The following is a description of a gene set: Reactome Pathway: Cytokine Signaling in Immune system Cytokines are small proteins that regulate and mediate immunity, inflammation, and hematopoiesis. They are secreted in response to immune stimuli, and usually act briefly, locally, at very low concentrations. Cytokines bind to specific membrane receptors, which then signal the cell via second messengers, to regulate cellular activity. part of: Immune System species: Homo sapiens, and this is the list of marker genes: TRIM48, PPP2CB, UBE2V1, MX2, PSMB6, PIK3R1, CNTFR, IL13RA1, SMARCA4, S1PR1, UBA52, ILF3, S100A12, TRAF2, CD4, UBB, GBP2, PELI1, IRS2, TYK2, VRK3, AKT3, PTK2B, PTPN13, IFNGR2, TUBB2A, SQSTM1, NKIRAS2, TNFSF18, GHR, NUP37, IL11RA, NUP205, IRF8, LCK, IL27RA, STAT1, TGFB1 (transforming growth factor beta 1), IL12B, GBP4, NPM1, PSMD14, UBE2D2, EDA2R, FAAP24, IL7, NUP42, PRLR, IFNGR1, SH2B1, CSF2RA, LTBR, CLCF1, CAMK2A, EIF2AK3, ADAM17, GRB10, RHOU, HGF, CCL22, FOXO1, CCL3L1, ITGB1, PSMB1, EBI3, MAPK9, ATF2, STAT3, CHUK, NUP35, EIF2AK2, NUP210, FNTA, PTPN18, IL6, IL13, IL15RA, TUBB2B, FANCM, PRL, HSPA1A, NCK1, EIF4A2, PTPN6, CD27, IKBKG, TIMP1, IFNA1, MSN, IP6K2, PTPN7, IL1RAPL1, UBE2I, PSMD6, FOS, UBE2N, POM121C, IL20, PIN1, SKP1, IL15, BCL2L11, CSF2, INPP5D, HNRNPF, MCL1, MAP2K6 (NCBI Gene Id 5608), IRF9, GH1, BCL2L1, FASLG, HSPA2 (heat shock protein family A (Hsp70) member 2), TNF, CCR1, IL18RAP, CAPZA1, IFIT1, NUP133, SYK, SNCA, YES1, SLA, TNFRSF4, NEDD4, MAPKAPK3, VTRNA2-1, PSMD7, PGGT1B, IRF4 (NCBI Gene Id 4592), TUBA1A, CDC42, SOX2, PTPN12, NUP93, HSPA1B, GBP1, OAS1 (2'-5'-oligoadenylate synthetase 1), LRRC14, MMP2, IFI35, RAP1B, PSMC2, MIF, ALOX5, TNFSF4, GAB2, TRIM25, IRAK3, FN1, PSMC4, EIF4A3, MAPK14, YWHAZ, IL21, HLA-DRB4, CD86, FANCE, IL36B, IL2RB, NDC1, PSMA2, IFNAR2, NFKBIA, PTPN14, TRIM35, HLA-B, FGF2, OPRD1, TRAF3, PELI3, TNFRSF25, IL6R, TALDO1, SPHK1, MAPK7, TNFRSF8, NUP88 (nucleoporin 88, NCBI Gene Id 4927), BECN1, CCND1, TNFSF14, PSMB7, NLRC5, KPNA4, NUP107, KRAS, PSMA3, GATA3 (GATA binding protein 3), TXLNA, IL9R, MX1, ISG20, CSF2RB, BLNK (B cell linker), SOS2, SERPINB2, TNFRSF14, FAAP20, IL17C, TUBA4A, PSMD3, CUL1, PRKACA, PDE12, IL2RG, GSTO1, LIFR, MUC1, OASL, AAAS, GBP5, IL12A, EIF4E2, IFNA16, JAK3, S100B, AKT2, MAP3K3, MAVS (mitochondrial antiviral signaling protein), FYN, RAG1 (NCBI Gene Id 5896), SOD2, IL33, BST2, IRF7, RNASEL, UBA7, ADRM1, CXCL2, AGER, SOCS3, CISH, CD40, FKBP5 (NCBI Gene Id 2289), TUBA3E, IL1RN, IL22, CNN2, RPS6KA3, ITGAM, IL1F10, CAMK2B, PTGS2, CSH1, IL7R, RSAD2, NUP188, TNFRSF1A, MEF2C, TNFSF13, IL27, EDA, HLA-DQA1, MID1, B2M, IFNG, IRF5, IL2, HLA-DPA1, TNFRSF17, APP, IFNA7, TUBB4A, SEC13, ABCE1, IFNA6, RANBP2, BCL6, KPNA2, STAT5B, LAMA5, CENPX, COL1A2, IL1R1, ARIH1, PLCG2, CSF1R, DHX9, NOS2, CD70, JAK2, BRWD1, CD80, IL19, HSP90B1, IL20RA, TNFRSF13B, CRK, PTPN23, STAT5A, IL17F, CCL3, TPR, PPP2R5D, PLCG1, CANX, OSMR, SOS1, ITGB2, TNFRSF6B, HSPA5, FCER2, Human respiratory syncytial virus A2, complete genome, XAF1, MAP3K7, PTPN20, PIK3R3, HAVCR2, gag, SLA2, UBE2D3, RPLP0, CCL11, MAPK1, NOD2, POU2F1, PELI2, IFI44, TUBB4B, MAP3K14, IGHG4, CCL5, MYC, IGHE, IL36A, NUP160, SNAP25, HMOX1, CCL4, NDN, EDAR, PDCD4, RELB, TRIM5, IL12RB1, IL17RA (interleukin 17 receptor A), SP100, PML, PPP2R1B, STXBP2, TNFRSF9, ARF1, RORC, HNRNPA2B1, CXCL1, TNFRSF12A, KPNB1, CCL2, CSF3R, ZEB1, EIF4G3, INPPL1, PSMD12, IL3 (NCBI Gene Id 3562), STX1A, RORA (RAR related orphan receptor A), IL25, FCGR1A, TUBB3, KPNA5, CCL19, SOCS5, IFNA5, IFIT3, IL12RB2, tat, UBE2L6, GBP7, CUL5, STAT4, IL9 (NCBI Gene Id 3578), CNTF, IFNA17, MAP3K8, PTPRZ1, TUBA3D, HLA-DQB1, CD44, UBC, MAP2K7, CRLF1, FCGR1B, HLA-DQB2, IFI27, HLA-G, AKT1, TRIM21, PPP2R5A, IFNL1, 8, FANCC, IFNL3 (interferon lambda 3), IL24, IL36G, HERC5, MAPK8, SNRPA1, ILF2, NUP98, MMP1, TAB1 (NCBI Gene Id 10454), IL17RB, BIRC3, IFNL2, HLA-DRA, EIF4E3, TRS1, RAF1, TNFSF9, CTF1, PIK3R2, MT2A, TRIM34, PSMB3, HLA-DRB5, TRIM22, IFITM1, IFI44L, LYN, TUBA3C, RELA, EIF4G2, RAG2, CD40LG, TAB3, RAE1, EIF2S2, TRIM62, DUS2, OSM, RPS6KA1, LGALS9, NOD1, IL16, UBE2D1, IFNB1, H3C15, CASP8, FBXW11, IL32, RBX1, CXCL8, IFITM2 (NCBI Gene Id 10581), IFNA4 (NCBI Gene Id 8006), JUNB (NCBI Gene Id 90482), FANCB, HLA-C, HLA-DRB1, CSK, IFNA14, ISG15, GRB2, UBE2E1, NUP62 (nucleoporin 62), PPM1B, SUMO1, TNIP2, ANXA2, NCAM1, OAS3, FNTB, PSMD13, RAPGEF1, CCR5, IL1B, TNFSF6, HLA-F, TUBB1, P4HB, NRAS, EDARADD, NUP155, ACTB, IL23A, TRIM31 (tripartite motif containing 31), DUSP3, IL34, TRIM14, NANOG, SH2B3, PSMA4, IRF2, PSMC1, PIM1, IFNLR1, PSMC5, SOCS6, IRF3, TNFRSF11B, PIAS1, IL17A, DUSP6, YBX1, TRIM38, IL11, TNFRSF1B, NFKB2, IL36RN, NUP58, IL1RL1, LMNB1, TARBP2, HSP90AA1, MTAP, AIP, PIK3CA, TRIM2, TRIM26, IL18, MAPK10, TP53, RPS6KA2, IFNA21, IL22RA2, EIF4A1, TRIM6, CTSG, TRIM3, GSDMD, PPP2CA, PSMC6, IRF6, ELOB, PSMB2, MAPK3, PSMA5, FLT3, IRAK2, IL10, HLA-DRB3, IFIT5, FOXO3, TUBB8B, IL18R1, USP18, NUP50, ICAM1, IL1A, IRS1, VAMP7, SDC1, SMAD3, TRAF6, H3C1, IL2RA, VP3, MAP2K4, EGR1, PIK3CB, MAPT, NS, PSMD2, HLA-H, PTAFR, THOC5, IFI6, PSME2, PSMD11, MMP3, TIFA, CFL1, HRAS, LBP, NLRX1, PTPN5, ITGAX, IFNA8, SRC, TRIM68, DNAJC3, TUBA1B, PPIA, IL10RB, OAS2, PSMA1, GRAP2, NFKBIB, TRIM45, CCR2, IL3RA, FANCL, NUP214, POM121, CSF1, SFN, PTPN1, TBK1, IRAK4, CDKN1B, NUP85, ALPK1, CRLF2, OPRM1, VEGFA, NKIRAS1, CASP3 (NCBI Gene Id 836), MAPK11, FANCG, PSMB5, KPNA1, FSCN1, KPNA3, TUBAL3, CD36, TNFSF11, IL23R (NCBI Gene Id 94006), STAT2, RNF7, SOCS2, TRIM29, TNFRSF13C, ATF1, HSPA8, IRF1, LCN2, ACTG1 (actin gamma 1), RPS6KA5, IL31RA, RALA, TSLP, LTA, CREB1, IL18BP, TUBB8 (tubulin beta 8 class VIII), N4BP1, IL17RE, SAA1, UBE2M, CIITA, CAMK2D, GBP6, CEBPD, GSTA2, BCL2, CXCL10, TUBA8, NUP153, CDK1 (NCBI Gene Id 983), UBA3, IL5RA, IL31, PSMB8, CRKL, KPNA7, PSMD8, TRIM10, VAV1, JAK1, MYD88, PTPRJ, RPS27A, FURIN, HLA-DQA2, HIF1A, PTPN4, CA1, EIF4E (eukaryotic translation initiation factor 4E), FANCA, JUN, IKBKB, TUBA4B, VCAM1 (NCBI Gene Id 7412), NUP43 (nucleoporin 43), IFIH1, TRIM8, DUSP7, MAP2K3, RIGI, TRIM17, TNFSF12, IL1RL2, TNFSF13B, BIRC5, HLA-E, PSMC3, N, IL10RA, CCL20, NFKB1, FANCF, SEH1L, TNFSF8, USP14, IL6ST, STX4, PTPN2, IFNA2, FCGR1BP, IL26, ELK1, IL22RA1, PRKCD, HSPA9, PRTN3, HMGB1, IFIT2, DUSP4, FLT3LG, EIF4G1 (NCBI Gene Id 1981), IL21R (interleukin 21 receptor), IL5, IRAK1, ANXA1, MAPKAPK2, TUBB6, ADAR, ATF6, IFITM3, IL17RC (interleukin 17 receptor C), IFNAR1, HCK, SEM1, EIF2S3, IL37, GAB3, PSMB4, IL1R2, IGHG1, CASP1, STX3, IL4, IFI30, FPR1, PSMD1, GBP3, SOD1, IL4R, TEC, RIPK2, SMAD7, VIM, BTRC, IFNA10, F13A1, PSMA7, LIF, TNFSF15, HLA-A, HSPA1L, TNFRSF11A, TRIM46, ELOC, TWIST1, BOLA2, ALOX15, PAK2, HLA-DPB1, PPP2R1A, PITPNA, TNFRSF18, MMP9, PTPN11, SHC1, GH2, MAOA, MEF2A, PSMA6, CAMK2G, STAT6, ABL2, IL13RA2, IL20RB, LTB, VAMP2, SOCS1, FAAP100, BATF, IL1RAP, POMC, LCP1, TAB2, HNRNPDL, CDKN1A, MAP2K1, PIK3CD, TUBA1C, CBL, EIF2S1, FLNA, CSF3, PRKRA, SAMHD1, CENPS, IKBIP, TOLLIP, BIRC2, TCP1, PTPN9, SIGIRR, NUP54, FLNB